Given this list of marker genes TFEB, GALNT10, ASAH1, CHFR, TNFSF10, HES1, ATP6V0D1, SORL1, SUSD6, TOP1, SMCO4, MOXD1, TLR7, LST1, DYRK2, VPREB3, PKIG, HCK, PLSCR1, SNRPN (small nuclear ribonucleoprotein polypeptide N), CDKN2A (NCBI Gene Id 1029), CTSH, NEDD9, INPP5D, DUSP1, TUBB6, VCL, KMO, RABEP2, RRAGC, DPYD, LTB, SLC12A8, BMP2K, F13A1, CHI3L2, KDM4B, NIPA2, here is a description of the gene set: Genes down-regulated in B lymphocytes from patients with primary immunodefiency syndrom. Human Gene Set: BOHN_PRIMARY_IMMUNODEFICIENCY_SYNDROM_DN Lysosome-related organelles have versatile functions, including protein and lipid degradation, signal transduction and protein secretion. The molecular elucidation of rare congenital diseases affecting endosomal-lysosomal biogenesis has given insights into physiological functions of the innate and adaptive immune system. Here, we describe a previously unknown human primary immunodeficiency disorder and provide evidence that the endosomal adaptor protein p14, previously characterized as confining mitogen-activated protein kinase (MAPK) signaling to late endosomes, is crucial for the function of neutrophils, B cells, cytotoxic T cells and melanocytes. Combining genetic linkage studies and transcriptional profiling analysis, we identified a homozygous point mutation in the 3' untranslated region (UTR) of p14 (also known as MAPBPIP), resulting in decreased protein expression. In p14-deficient cells, the distribution of late endosomes was severely perturbed, suggesting a previously unknown role for p14 in endosomal biogenesis. These findings have implications for understanding endosomal membrane dynamics, compartmentalization of cell signal cascades, and their role in immunity. studied in species Homo sapiens from publication Bohn G, Allroth A, Brandes G, Thiel J, Glocker E, Schäffer AA, Rathinam C, Taub N, Teis D, Zeidler C, Dewey RA, Geffers R, Buer J, Huber LA, Welte K, Grimbacher B, Klein C (PMID 17195838)